The following is a description of a gene set: Aplasia/hypoplasia involving the skeleton studied in species Homo sapiens Human Gene Set: HP_APLASIA_HYPOPLASIA_INVOLVING_THE_SKELETON Absence (due to failure to form) or underdevelopment of one or more components of the skeleton., and this is the list of marker genes: LTBP4, COL9A1, BCL11B, NTNG1, DPH1, ANKLE2, SETD5, SHOX, PEX19, RTTN, TPM3, GPX4, ALG13, CTU2, FBXO11 (F-box protein 11), B3GLCT, CEP290, TBC1D20, DPAGT1, MBD5, BBS1, FUCA1, TBC1D24, MMP2, CUL7, EYA1, PIEZO2, SOX11, HNRNPH2, UBA1, MMP23B, CBL, FLVCR2, CTBP1, PRKG2, EDA, PNKP, CPLANE1, MYMK, RAB34, HDAC8, SALL1, PIGN, RPS28, HNRNPR, ALG14, MAFB, MAP3K20, LRP4, COL9A3, MIPEP, EPG5, RPL35, CHRND, SPEG, MYH8, DYNC2LI1, FGD1, TONSL, SLC5A7, CCNQ, MYMX, RAB18, COL13A1, JMJD1C, COX4I1, EXT1, EXT2, FLNB, DCHS1, WIPI2, PIGW, POU1F1, PPP1R15B, OTX2, CEP55, GNPTAB, CPLX1, PIK3R1, SSR4, SMC5, PAX6, TBXT, VANGL1, IGF1R (NCBI Gene Id 51049), TBCE, RPS26 (NCBI Gene Id 6231), BCAP31, TBX15, STXBP1, KIF22, KIAA0586, GTF2E2, TMEM70, ALOXE3, TMCO1, COG4, ASPH, CFL2, FGF9, PHOX2A, CERT1, H4C3, JAG1, PRKACB, CAMK2G, NFASC, CARS1, CENPE, GABRD, HINT1, KIAA0753, POLR1B, DNAI1, KDM5C, PI4KA, KCNK4, STAG2 (NCBI Gene Id 10735), TPR, NIN, BGN, TPRKB, PEX6, FLNA, TAF1, PRRX1, SEC24D, MAPRE2, FGFRL1, CLCN7, MIR140, D2HGDH, HELLS, PPP1R12A, CUL3, SUZ12, MAD2L2, EIF4A2, SMAD4 (NCBI Gene Id 4089), RPL11, FTSJ1 (FtsJ RNA 2'-O-methyltransferase 1), SEMA5A, SON, RAP1B, NEPRO, PLAGL1, PRKCZ, LRRC32, ARCN1, XRCC4, COMP, FILIP1, GNPAT (NCBI Gene Id 8443), C1S, KDM6A, WDR11, CTSK, ALG12, ERCC1, SPRED2, PGM1, SPECC1L, LTBP2, GJB6, BUD23, OCA2, BMPER, DYNC2I1, RPS17, GTF2IRD2, FGF16, C1R, AFF3, PIGS, MYO9A, NOTCH2, RSPO2, SNORD116-1, GPKOW, CDK5, ALMS1, RDH11, WDR62, CASZ1, MCM5, GUSB, SMARCC2, DNMT3A, COL1A2, BCL11A, OBSL1, LHX3, PKHD1, AGA, RBM8A, CNTNAP1, SIL1, NEDD4L, PUS1, VPS53, ERMARD, CNOT3, ZBTB18, EXOC6B, ADAMTSL2, VANGL2, NSD1, SLC25A19, PIGT, BRIP1, B2M, SLC31A1, CSNK2A1, SATB2, NRCAM, UBE4B, KAT6A (NCBI Gene Id 7994), NSUN2, CWC27, SH3PXD2B, ARHGAP31, KIDINS220, SLC37A4, SMO, NSD2, ANTXR2, RB1, BRCA1, DVL3, ADA2, MEGF8, FGFR1, SNRPB, FKBP10, GLDN, SIX2, TASP1, EOGT, TRPM3, PUM1, MRAS, VPS35L, ZNF668 (NCBI Gene Id 79759), STX16, VAMP1, GRIN1, H4C9, CEP152, PGAP2, CSPP1, CUL4B, BRD4, USP9X, BICRA, PPP3CA, EP300, PLK4, PTH1R, MAPK8IP3, CCN6, MYCN, CACNA1C, FKTN, WNT10B, NGLY1, KIFBP, NCAPG2, TRAIP, ZC4H2, ESAM, NEK9, WNK3, ZDHHC9, NUP107, SCN1B, PWRN1, CHD4, CPE, PIGP, DLX5, FKBP6, GDF11, LEMD2, MAB21L1, COL1A1, FBN1, EIF2AK3, TMEM67, FIG4, SFRP4, ZBTB24, TSEN54, ERCC2, ZMYM2, DPYD, EDA2R, ACTL6B, RPS27, ERCC5, GNAO1, HBA2, PIGB, POLE, SVBP, WNT5A, RARB, SLC35D1, CDT1, ALOX12B (arachidonate 12-lipoxygenase, 12R type), EDN1, SMG8, MARS1, SPRTN, TTN, RAB3GAP2, AKT1, MECOM, PEX14, NIPBL, KATNB1, UBE2A, LMX1B, DSTYK, PQBP1, NRAS, FREM2, SELENON, FN1, ERGIC1, MAGEL2, TXNDC15, CCL2, CDC42BPB, KCNN3, ELN, HBA1, KMT2D, ATRIP, H3-3A, CAPRIN1, AP1G1 (adaptor related protein complex 1 subunit gamma 1), AIFM1, CD96, PORCN, GAD1, SH2B1, BRCA2, AGPS, SLCO2A1, CREB3L1, FBXW11, PHGDH, FBXL4, CCDC32, DYNC2H1, EIF4H, FGFR3, SCN2A, PDGFRB, CDCA7, LEMD3, RASA2, ABCA12, LMBR1, DPF2, BPNT2, ARID1B, CNOT2, ROR2 (receptor tyrosine kinase like orphan receptor 2), ADAMTS10, NECTIN1, PLCB4, CRKL, RPL10, IQCE, BUB1, GPC3, MYSM1, FBN2, ADAT3, WAC, PRKAR1A, KIF14, YARS1, TMEM216, VPS13B, SPOP, THOC6, RPS19, RINT1 (NCBI Gene Id 60561, RAD50 interactor 1), RIT1, VARS1, ZNF699, FOXI3, PRORP, ASXL2, ADGRG6, SNRPN, RPS29, ZMIZ1, UBE3B, ASXL1, DNA2, P3H1, SOX9, IKBKG, GP1BB, TGFB1, PLAG1, DLL4, EFTUD2, EZH2, YARS2, GNA11, RUNX2, SLC26A2, ZFX, TOPORS (NCBI Gene Id 641432), FUZ, HRAS, WDR73, SIX1, KPTN, NANS, TFAP2B, EXTL3, RELN, HESX1, RAB33B, KNSTRN, POMGNT1, PDE6D, ERCC3, RIPK4, CCDC8, HEATR3, PLAA, COL3A1, RREB1, NXN, TCTN2, FANCI, CHUK, NDUFB11, MNX1, IFT122, GJB2, BUB1B, SLC32A1, GABBR2, KDM1A, COG7, ACTG1, ESCO2, MACROH2A1, TELO2, COL11A2, BMPR1B, PHF21A, SUMF1 (sulfatase modifying factor 1), ACP5, TMEM231, DSE, RPS6KA3, TRIM8, EFNB1, SMARCA4, SMC1A, CFAP410, DDR2, MIR17HG, IDH2, PROP1, AEBP1 (AE binding protein 1), GNPNAT1, TOE1, PAM16, ITPR1 (NCBI Gene Id 619543), FBXW4, PRIM1, NKX2-6, RRAS2, B4GAT1, ABCD1, POP1, IFT81, HYLS1, RPS10, POMT1, HOXA13, KLHL41, PI4K2A, TGFBR2, CCDC28B, PIGO, ASAH1, NAA10, PTDSS1, CHD5, EFEMP2, OFD1, GATAD2B, ADA, FANCB, TUBB, WDR26, LONP1, SNAP25, ANTXR1, RFC2, ORC4, SCN4A (NCBI Gene Id 6329), DZIP1L, GLI3, CRIPT, PEX2, CLPB, NOG, CCN2, ARX, SLC35C1 (NCBI Gene Id 55343), DOK7, PWAR1, STX1A, MYH7, PEX26, KLHL15, FANCF, KDM4B, DLX6, SRPX2, DYNC2I2, DNAJC21, TXNL4A, EMC1, RAD51, GJA5, CHD6, SMARCB1, FANCD2, CLCN3, BUB3, NUP88, NDE1, ARVCF, CTDP1, RPS24, SRY, SPRED1, ALX1, RBBP8, TMEM53, TBL2, XRCC2, IGF1, SLX4, CRTAP, LRPPRC, MRPS28, IFT57 (intraflagellar transport 57), PRKACA, ALDH18A1, VPS33B, TCOF1, LHX4, TMEM107, TBCD, YY1AP1, PIK3CA, KCNJ6, RAG2, DHODH, PALB2, HHAT, ANK1, OSTM1, NSMCE2, ZNF335 (zinc finger protein 335), RAD51C, FAT4, TBX6 (T-box transcription factor 6), GTF2H5, CCDC47, LETM1, HMGA2, DHCR24, FLCN (NCBI Gene Id 201163), BDNF, CLCF1, COL2A1, ARID2, PRMT7, GHR, CTCF, FOXC2, DNMT3B, GSC, NOTCH1, GTF2IRD1, TCTN1, RNU4-2, IRX5, SIK1, CHD7, ALG9, SLC25A24, IPO8, GLUL, YY1, RSPRY1, NUP85, TTC21B, WASF1, RIN2, CTNND2 (NCBI Gene Id 1501), ALDH1A2, BANF1, MITF, MYOD1, B3GAT3 (NCBI Gene Id 26229), TBX22, HPGD, PRUNE1, MBTPS2, TP53RK, RPL9, METTL27, PEX16, MKRN3, ALX4, NODAL, NEUROD2, WLS, RAC3, ANKRD11, PEX3, ASPM, KNL1, KCNJ5, ECEL1, POLR1A, RNF113A, COL12A1, FAM149B1, RPS20, PPP2R3C, CDH11, PHYH, TSR2 (TSR2 ribosome maturation factor), SF3B4, DPH2, SOX4, ASNS, PAICS (NCBI Gene Id 647765), PDE4D, NEB, TAPT1, ANAPC7, COL10A1, GRB10, PSMB8, WNT7A, PHIP, MYO18B, NHS, SCO2, PEX1, FANCL, SOS1, SHANK3, ERI1, IFNGR1, GDF5, HYMAI, FERMT1, MTOR, MEIS2, ATR, SERPINH1, GNAS, BMPR1A, MINPP1, GLE1 (GLE1 RNA export mediator), COG8, NBN, PIEZO1, RAD21, PHF6, PYROXD1, TCF4, SNORD115-1, GNS (NCBI Gene Id 2799), RPGRIP1, ERCC4, CHN1, DNAJC30, PEPD (NCBI Gene Id 84738), CA2, ERCC6, FANCC, FZD2, PITX1, HMX1, BLM, GLI1, NCF1, LARGE1, SP7, ZSWIM6 (NCBI Gene Id 57688), B4GALT7, DKC1, SHH, AFF4, ACBD6, MYPN, LBR, RPGRIP1L, SLC6A17, CHST3, STAMBP, P4HB, DEAF1, SPART, ARID1A, PDHA1, KRAS, PRG4, RAG1, AARS1, KCNJ2, FOCAD, POC1A, WWOX, CHRNG, TMEM237, ARL6, COX7B, CDC6, NSDHL, PEX13, ARMC9, IFT80, GABRA3, TGDS, PCYT1A, C2CD3, YRDC, SOS2, FANCM, CRELD1, KIF21A, WDR81, PEX11B, GMNN, MYL2, LIMK1, PAK2, POLR3A, ERBB3, BMP4 (NCBI Gene Id 652), RPL31, COL6A1, SEC31A, GOLGA2, HERC2, SIN3A, LIFR, MAD1L1, SLC39A8, CTC1, HCCS, LAMA5, CBFB, NDN, FBXO28, LZTR1, PRDM13, PIGG, SMAD2, PEX5, MET (MET proto-oncogene, receptor tyrosine kinase), FANCG, IL7R, PIK3C2A, TBX1, PAPSS2, TUBB2B, PCGF2, DVL1, PSAT1, GBA1, PIGQ, TRRAP, RPL18, GALNT2, CILK1, PIGL, MSX2, SLC25A22, TRPV4, SIM1, KCNH1, MBTPS1, TOR1A, PSMD12, LMNB2, NBAS, ORC6, GALNS, MADD, FLI1, PEX10, COASY, PIGY, RTL1, TNNT3, UHRF1, UNC80, ARSL, HSPG2, ZMPSTE24, KAT6B, IFT52, PTEN, SLC2A10, SRCAP, AHDC1, TRIP4, DIS3L2 (DIS3 like 3'-5' exoribonuclease 2), FGF3, PIGF, PIK3CD, COL5A1, ATRX, MAPK1, FRAS1, POLD1, MAP3K7, PTHLH, RNU12, GPC4, RAB23, GJA8 (gap junction protein alpha 8), DPM2, BHLHA9, SUCLG1, SUPT16H, MMP13, PLA2G6, FOXF1, GPC6, BTRC (NCBI Gene Id 8945), ARL6IP6, SIK3, MASP1, CAMK2A, EBF3, COL11A1, POMT2 (protein O-mannosyltransferase 2), MTX2, HYOU1, PKDCC, SMOC1, CAMTA1, DPYSL5, SMARCE1, IQSEC2, NALCN, BRAT1, PDPN, TNFRSF11A, CSGALNACT1, SMC3, ADAMTS2, TGFBR1, RPL8, RERE, DYM, PLCB3, COL25A1, PAH, OSGEP, UBAP2L, HTT, GNAI3, ASXL3, CHST14, KCNK9, NELFA, ARSB, PPIB, UPF3B, KYNU, GRM7, CLIP2, ATP6V1B2, DCLRE1C, PDE3A, CANT1, PEX12, MPLKIP, KDM5A, MCTP2, TP63, IDUA, TARS1, INTU, GLB1, SEC24C, HUWE1, HEPHL1, DYNLT2B, FUT8, LTBP3, DPH5, MGP, MIA3, SOX6, FANCE, TCTN3, GJA1, EIF5A, ERF, RFT1, TNFRSF11B, NF1, INPPL1 (inositol polyphosphate phosphatase like 1), TRAPPC2, PIGV, GEMIN4, POGZ, B9D1, CEP295, PTCH1, RNF2, HNRNPU, LIG4, DYNC1H1, EBP, AMER1, ZBTB20 (NCBI Gene Id 26137), BAZ1B, ACTG2, AFG2B, GTF2I, TGFB3 (NCBI Gene Id 7043), SLC39A13, PIGA, UBR7, ATAD3A, TMEM270, TCIRG1, LGI4, DYRK1A, EIF4A3, FGFR2, KIF5C, ALG1, SLC25A1, WNT3, PSMC1, PTPN11, BPTF, GRIP1, SEM1, SMARCD1, FMR1, TUBB3, IFT140, COG1, PURA, EVC, BLTP1, KCNJ8, SLC29A3, DDRGK1, NEK1, SLC18A3, RBM10, SMAD3, KCNA1, ABCD4 (NCBI Gene Id 5826), HSD17B4, SYT2, ROBO1, SCUBE3 (signal peptide, CUB domain and EGF like domain containing 3), TRAF3IP1, REV3L, EDNRA, EPS15L1, WT1, MAP2K1, GNAS-AS1, MED12, STRA6, ATP6V0A2, DICER1, DHCR7, MTHFS, CC2D2A, LFNG, RBPJ, PLVAP, LMBRD2, POLA1, CCBE1, FAM20C, ZIC3, WDR35, DONSON, SCYL2, PCNT, LMNA, PGAP3, SLC35A2, ACAN, WDR4, PUS7, VAC14, MAB21L2, CHSY1, TBCK, MKS1, SLC10A7, RPL26, PPOX, PLXND1, DLK1, TENT5A, NOTCH3, TOMM7, CDKL5, CDK10, ADGRG1, FKRP, SMCHD1 (NCBI Gene Id 2490), RAB3GAP1, MATN3, RLIM, SLC35A3, HECTD4, UFD1, ALG6, SF3B2, TFAP2A, LMOD3, UBE2T, MYH3, TNRC6B, ACVR1, TRPS1, HOXD13, RPL5, CHRNA1, RYR3, HDAC9, DACT1, DDX3X, POR, GATA1, GATA4, WDR19, ATP6AP2 (NCBI Gene Id 95880), TRIO, ORC1, DOCK6, INTS1, HACD1, CHAT, KCNAB2, ACTA1, TBL1XR1, RHOBTB2, ZNF407, SKI, HIRA, KMT2A, FAM50A, CRLF1, STAG1, EVC2, HDAC4, CHD8, TAF6, TBX5, LAS1L, GGCX, POLR1C, ABCC9, CEP57, TRMT10A, SCARF2, MECP2, TBX4, KIF26A, CACNA2D1, TBX3, ASCC3, IRF6, ZNF341, ACTB, FDFT1, MUSK (muscle associated receptor tyrosine kinase), SIX6, MMP9, WASHC5, TRIP13, LUZP1, RAPSN, CREBBP, RFWD3, BRF1, MEG3, FRA10AC1, CENPJ, SOX2, APC, GNB2, HOXB1, NPR2, AUTS2, OCRL, ATP7A (NCBI Gene Id 613259), ALPL, KBTBD13, CASK, TNNI2, OCLN, MID1, HES7, SMARCA2, XYLT1, IGF2, CHST11, TPM2, COL6A2, CENPF, COL6A3, COMT, SLC35B2, NFIX, BCOR, LAGE3, SPEN, VPS37D, POLR1D, IFT43, FANCA, RAI1, LZTFL1, MSL3, PAX1, PSPH, B9D2, C12orf57, MYF5, RPL35A, CEP120, PPM1D, ZNF292, SETBP1, RMRP, BICD2, DMXL2, IGFALS, B3GALT6, SNIP1, GON7, RPL27, TRPV6, ANAPC1, RRAS, RPS7, PUF60, KIF15, AGRN, MTFMT, COL9A2, MAN2C1, CDKN1C, ITGA7, NUP133, MYBPC1, NKX3-2, NPAP1, DPM1, AMMECR1, ALX3, CDC45, LRP2, BMP2, EN1, RNU4ATAC, SC5D, RPS15A, TGFB2, KIF7, IL2RG, FGF10 (fibroblast growth factor 10), FBXL3, RPL15, EMG1, WRN, TRIM37 (NCBI Gene Id 4591), HDAC6, FLII, USB1, TWIST2, SETD2, CLDN16, PAX7, IDH1, ADNP, RAC1, RAF1, PEX7, MSTO1, IARS2, TUBA1A, SALL4, ATPAF2 (NCBI Gene Id 91647), IFT172 (NCBI Gene Id 26160), CCDC22, BRAF, HAAO, IHH, STAC3, USP7, SATB1, TWIST1, TRIP11, PRDM16, CLTCL1, BCR, ADAMTS17, RECQL4